The following is a description of a gene set: Unilateral renal hypoplasia Human Gene Set: HP_UNILATERAL_RENAL_HYPOPLASIA One sided hypoplasia of the kidney. species: Homo sapiens, and this is the list of marker genes: MCM5, HRAS, PLXNA1, C2CD3 (NCBI Gene Id 26005), H4C5